Given this list of marker genes MAGI3, DVL1, WNT10A, DVL3, ZNRF3, WNT5B, MYOC, WNT9B, LRP6, WNT7A, DVL2, SDCBP, FZD1, WNT16, CCDC88C, WNT2, WNT6, CTHRC1, WNT9A, WNT7B, WNT3 (NCBI Gene Id 7473), APP, WNT2B, WNT10B, SFRP1, WNT3A, FZD7 (frizzled class receptor 7), WNT8A, NDP, WNT5A, RNF43, BAMBI, RSPO3, WNT11, TMED2, WNT1, WNT8B, RYK, WNT4, here is a description of the gene set: species: Homo sapiens Human Gene Set: GOMF_FRIZZLED_BINDING Binding to a frizzled (fz) receptor.